Given this list of marker genes Rab11a, Zfp955b, Jph1, Tgfbi, Slc30a10, Pdcd4, Ndufv2, Necab1, Mprip, Tipin (timeless interacting protein), Edil3, Kdm7a, Acsm2 (acyl-CoA synthetase medium-chain family member 2), Tsga10, Fsd1l, Cwh43, Pbrm1, Hnrnpk, Zfp27, Yap1, Pcsk6, Peli1 (NCBI Gene Id 77964), Arhgap24, Yod1, Bcl7a, Nkiras1, Dlgap1, Tmem170, Fasl, Fmn1, Fa2h, Osr1, Smad7, Frat1, Tmtc3, Epha4, Pnpt1, Glcci1, Btg2, Gramd2b, Reck, Caskin1, Lsm5, Mindy2, Cpeb3, Ski, Armcx1, Fgf18, Ipo11, Map3k1, Adgrg2, Ifrd1, Mreg, Crebrf (CREB3 regulatory factor), Tmem236, Plxna2 (plexin A2), Gm4894, Ccl20, Rbms3, Dusp8, Zfp367, Acvr2a, Ube2d3, Nfib, Pitx2, Tent5a, Vcl, Rasgrp1, Rmnd5a, Ppp1r3b, Pcmtd2, Ankrd49, Bcl11b, Glis2, Il21, Spry1, Ccl1, Prkci, Ubr3, Nfia, Stag2, Armcx5, Edrf1, Hnrnpu, Sox5, Ntf3, Zdhhc17, Fnip1, Pan3, Ank2, Mbd4, Ehd1, Matn2 (NCBI Gene Id 17181), Ndnf, Akap6, Spink14, Sc5d, Zfp229 (zinc finger protein 229), Map2k3, Sema5a, Srl, Pcbp2, Dmrtc2, Rsad2 (NCBI Gene Id 72445), Fgd4, Pja2, Ppp1r3a, Ranbp3l, Scml2, B3galt1, Spry2, Nectin3, Pik3r1, Hipk3, Dvl2, Il12a, Elf2, here is a description of the gene set: Mouse Gene Set: MIR_21A_5P species: Mus musculus Genes predicted to be targets of miRBase v22 microRNA mmu_miR_21a_5p in miRDB v6.0 with MirTarget v4 prediction scores > 80 (high confidence targets). from publication Chen Y, Wang X (PMID 31504780)